The following is a description of a gene set: species: Homo sapiens Catalysis of the reaction: a 1-acyl-sn-glycero-3-phosphocholine + H2O = a fatty acid + H+ + sn-glycerol 3-phosphocholine. Human Gene Set: GOMF_LYSOPHOSPHOLIPASE_ACTIVITY, and this is the list of marker genes: LYPLA1, ENPP2, PNPLA8, PLB1, PLA2G4A, GDPD3, ABHD12B, LYPLAL1, LGALS13, MGLL, PLA2G4B, GDPD1, LYPLA2, PNPLA6, ASPG, ABHD16A, LIPC, PLA2G4F, PLA2G15, GDE1, ABHD4, PNPLA7, PLA2G6 (NCBI Gene Id 8398), PLA2G4C, ABHD12, CLC